The following is a description of a gene set: from publication Baram D, Dekel O, Mekori YA, Sagi-Eisenberg R (PMID 20190146) Human Gene Set: GSE19888_CTRL_VS_A3R_ACTIVATION_MAST_CELL_UP species: Homo sapiens Genes up-regulated in HMC-1 (mast leukemia) cells: untreated versus Cl-IB-MECA. We demonstrate that the G protein Gi3 is the cellular target of the adenosine A3 receptor (A3R). By using a cell permeable peptide comprising the C-terminal end of Gαi3 fused to an importation sequence (ALL1) as a selective inhibitor of Gi3 signaling, we show that by coupling to Gi3, the A3R stimulates multiple signaling pathways in human mast cells, leading to upregulation of cytokines, chemokines and growth factors.Following contact with activated T cell membranes, endogenous adenosine binds to and activates the A3R, resulting in Gi3-mediated signaling. Specifically, the majority of ERK1/2 signaling initiated by contact with activated T cell membranes, is mediated by Gi3, giving rise to ALL1-inhibitable cellular responses. These results unveil the physiological GPCR that couples to Gi3 and establish the important role played by this G-protein in inflammatory conditions that involve adenosine-activated mast cells. We used microarrays to detail the effect of ALL1 on gene expression of HMC-1 cells activated directly by the A3 receptor, or by contact with activated T cell membranes., and this is the list of marker genes: FIRRE, CHTF8, KIF21B, RAD51AP1, SLAMF8, HMGB3, DPM1, PSMB2, FBXL20, TRIM28, HMGXB3, STXBP4, ERCC4, STARD5, PRR3, HMG20A, COL7A1, TMCO6, NRF1, SHARPIN, UTP15, KNOP1, TNK2, PRPH, MYL12B, OTOR, CRTC3, BDKRB2, TTN, GPT, NOS1AP, SH3RF1, NHSL2, SLF2, FAF2, IL17RE, CCDC136, DDX17, KIAA0319L, KLF11, VAMP1, SECTM1, DPH7, MEF2D, CENPL, ARF3, CHD2, MGST3, RAD54B, CALR, ZNF512B, SIPA1L2, ZSCAN12, IPCEF1, FOXS1, RNF187, CENPO, MAFG, WNT4, MTMR3, FAM83D (NCBI Gene Id 81610), DGKZ, RANBP10, UCN2, COPA, TSPYL2, CCNT2, ANKRD16 (ankyrin repeat domain 16), GAS1, UQCRC1, TIAM2, MAP4K2, FAT1, RGS11, MDH2, TRMT112, GORASP2, NEAT1, MAP3K4, ZNF385B, ZFP28 (NCBI Gene Id 57588), ARFRP1, STRN4, RPAP1, KRT6A, DAG1, CAPN6, SRRT, ATP1B3, PACRG, CHD8, TTC5, KIF18B, CYC1, FLNC, BCL2L12, TGM5, DDX11, CKAP5, RNF215, PLXNA3, CHUK, METTL17, KLHDC1, SAMD11, PICK1, PLK1, KHDC4, DEPDC1B, WARS1, CENPM, DTX4, NLRC5, VANGL1, ATAT1, IL17RB, POU5F2, ARGLU1, CFTR, HHIP, B2M, C9, GPC4, UNC119B, LUC7L, ADSS2, TBCD, NEB, RBM25, SUN2, RUNX2, MYLK, ZMYND8, PI4KB (phosphatidylinositol 4-kinase beta), PLEKHM2, SERBP1, ILF3, UPP1, UBC, FHIP2B, PNKD, AMFR, RTN4, RBM5, ZNF692, BAZ2A, KDM3B, TBX1, SYPL1 (NCBI Gene Id 6856), EFR3A, CXCL9, ADGRL1, RPS2, SF3B3, ZFP41, STRADA, ASIP, SCARB2, COPG2, SLC25A3, OVGP1, CCNL2 (cyclin L2), TUBB, MDC1, KCNQ1OT1, PRRC2B, TAP1, ATP6V0C, ZNF106, PSMB8 (proteasome 20S subunit beta 8), NPNT (NCBI Gene Id 255743), TUBB4B, KCNMB4, STAT2, SETD7, THRAP3, CNOT1, AOPEP, HOXA7, AGO4, DFFA, IGSF3, NXN, FITM2, ZFYVE1, IGSF9B, ANAPC5, ARF1, SVIL, TNC, CAT, MAP3K20, PTCD2, INSYN2A, TRIM8, TRIM63, CCDC62, ARHGEF18, HSD17B6